The following is a description of a gene set: Citrate cycle, second carbon oxidation 2. Pathway ID: N01617. Pathway type: Reference. Pathway class: nt06031 Citrate cycle and pyruvate metabolism. Human Gene Set: KEGG_MEDICUS_REFERENCE_CITRATE_CYCLE_SECOND_CARBON_OXIDATION_2 species: Homo sapiens Pathway Definition from KEGG: SucCoA -- SUCL >> SDH >> FH >> MDH1/2 -> OA, and this is the list of marker genes: SDHD, FH, SDHC, MDH1, SUCLG2, SDHB, SUCLA2, MDH2, SDHA, SUCLG1